The following is a description of a gene set: Human Gene Set: MODULE_175 studied in species Homo sapiens Genes in the cancer module 175., and this is the list of marker genes: CYLC2, ZBTB16, SNTA1, HOXB5, IL15RA, COL18A1, COG2, HTR3A, TCN1, RAB4A, LTBP1, EPHA2, CX3CL1, ZNF212, MTF1, PLOD1, PHLDA1, TAX1BP3, ANK1, TRIP10, GPR176 (NCBI Gene Id 11245), KLHDC3, SLC11A1, TNNT3, CD3G, TERT, CD1C, TRIM29, TCP10L3, TM4SF4, PRKCH, THBS4, CR2, AOAH, IL2RB, POLR2C, PDE2A, IL6R, SP140, GPR183, RGPD5, CACNG1, UBE2G1, SEMA4D, TNK1, ARHGAP35, CCR1, PLOD2, HRC, DHCR24, HMGCR, AQP1, PPARD, IGF1R